The following is a description of a gene set: Human Gene Set: MASSARWEH_TAMOXIFEN_RESISTANCE_UP species: Homo sapiens Genes up-regulated in breast cancer tumors (formed by MCF-7 xenografts) resistant to tamoxifen. from publication Massarweh S, Osborne CK, Creighton CJ, Qin L, Tsimelzon A, Huang S, Weiss H, Rimawi M, Schiff R (PMID 18245484) Not all breast cancers respond to tamoxifen, and many develop resistance despite initial benefit. We used an in vivo model of estrogen receptor (ER)-positive breast cancer (MCF-7 xenografts) to investigate mechanisms of this resistance and develop strategies to circumvent it. Epidermal growth factor receptor (EGFR) and HER2, which were barely detected in control estrogen-treated tumors, increased slightly with tamoxifen and were markedly increased when tumors became resistant. Gefitinib, which inhibits EGFR/HER2, improved the antitumor effect of tamoxifen and delayed acquired resistance, but had no effect on estrogen-stimulated growth. Phosphorylated levels of p42/44 and p38 mitogen-activated protein kinases (both downstream of EGFR/HER2) were increased in the tamoxifen-resistant tumors and were suppressed by gefitinib. There was no apparent increase in phosphorylated AKT (also downstream of EGFR/HER2) in resistant tumors, but it was nonetheless suppressed by gefitinib. Phosphorylated insulin-like growth factor-IR (IGF-IR), which can interact with both EGFR and membrane ER, was elevated in the tamoxifen-resistant tumors compared with the sensitive group. However, ER-regulated gene products, including total IGF-IR itself and progesterone receptor, remained suppressed even at the time of acquired resistance. Tamoxifen's antagonism of classic ER genomic function was retained in these resistant tumors and even in tumors that overexpress HER2 (MCF-7 HER2/18) and are de novo tamoxifen-resistant. In conclusion, EGFR/HER2 may mediate tamoxifen resistance in ER-positive breast cancer despite continued suppression of ER genomic function by tamoxifen. IGF-IR expression remains dependent on ER but is activated in the tamoxifen-resistant tumors. This study provides a rationale to combine HER inhibitors with tamoxifen in clinical studies, even in tumors that do not initially overexpress EGFR/HER2., and this is the list of marker genes: NFIX, SDC1 (syndecan 1), EPN3, USP54, PTPN13, PLBD1, SAT1, COL5A2, VASN, CENPV, CREB3L2, ORMDL3, NUCB2, MTMR12, MYO1B, ALCAM, MIOS, DHRS3, STK38L (serine/threonine kinase 38 like), CD55, TENT5A, TLN2, RAD23B, LITAF, C6orf120, OTUD7B, SH3BP4, YIPF6, MIR99AHG, NUPR1, RFTN1, XPNPEP1, AR, JKAMP, CYB561, MIPEP, DIPK1A, EDN1, P2RY2, APELA, H2AC18, BCAP29, IDH1, NPR2, CCPG1, IQGAP2, POGLUT3, COL1A2, CDC37L1, TNS3, SYT7, KLF12 (KLF transcription factor 12), YIPF1, LIMCH1, ANKRD22, PIP4K2C, KLHL8, DNAJA4, B3GALT4, WDR45B (NCBI Gene Id 56270), TTC9, SHANK2, SGMS2, RORC, RELCH, CYP2J2, SLC12A5, SLC12A2, HOXA5, PRDM4, BET1L, PRPS1 (phosphoribosyl pyrophosphate synthetase 1), FAM210B, LOXL1, GAN, SCHIP1, CAB39, PDGFRA, ARHGEF37, FAM219B, SYNJ1, SCARA3, USB1, CFL2, AGMAT, ZNF70, ACVR2A, SFMBT2, DPY19L4, TYW5, TENT4B, RAB27B, MUC1, TIMM23B, SLC22A15, SRARP, FFAR2, FBXO6, SAR1B, EPAS1, TPMT, TXNDC5, TMEM50A, OSR2, EPS8L1, MTUS1, MTURN, ZNF704, IDH2 (isocitrate dehydrogenase (NADP(+)) 2), MTA3, PYM1, ATP2B1, RNF144B, RASL11B, FGD6, RAD18, DLX1, TSPAN1, EOGT, PMP22, GALNT3, C3orf70, CTSO, SWAP70, MUC2, ID2, ZFP36, PSTPIP2, SPRING1, LIMK2, SMIM7, MMAA, SQOR, TIMP2, SGPL1 (sphingosine-1-phosphate lyase 1), TACC1, TOMM40L, KIAA0513, NFIA, PITX2, UNC13B, ENC1, IRF2BPL, DOCK11, HOXC13, SLC37A1 (NCBI Gene Id 54020), PTPRJ, OXCT1, OLFML2B, USP53, GALNT1, TRIQK, PPM1L, TGFB2, CLCN3, ARRB1, STX12 (syntaxin 12), UQCC1, GUCY1A2, GPR157, GREB1L, CDH3, PRICKLE2, AGAP4, SASH1, KDELR2, OLFML2A, COBLL1, SMAP2, LRRC1, GNA12, CPD, MTERF4, INPP4B, SCCPDH, ZNF697, FHIP2A, KIAA1217, TRAK1, IER3, HOTAIRM1, GPC1-AS1, TMEM41B, GABARAPL1, MIGA1, COLEC12, HNRNPC, RASGEF1A, KRT13, ACACA, STN1, WDR90, TM9SF3, GAREM1, IL13RA1, KRT81, ATG2B, TRAF5, EMP1, HS6ST2, GADD45G, VPS13B, PTPN14, HOXA10, CBR1, MATN3, PRMT9, DENND3, RAB1A, DSCR8, SMPD1, H2BC4, DEGS1, TMEM39A, NIPAL3, RHOF, GATA2, MEF2A, LRRC8E, RND3, ACSL1, RASSF5, PSEN1, GFPT1, NEBL, PDXDC1, ADAM9, TNFSF10, HACD2, ERBB2, BMAL1, RICTOR, VSIG10, ATXN1L, SLC25A16, BCL6, H3-3B, RBMS1, LIMA1, PCTP, C6orf62, FAM13A, SNX13, SPTY2D1, MPZL2, PARM1, ATP8A1, LIX1L, WLS, S100P, IL1R1, SPINK4, BEX2, NCEH1, JAG1, ANOS1, LOX, FAM20C, SLC11A2, ZNF550, NUDT4, TRAM2, TRAM2-AS1, PLEKHA7, TMEM8B, MYCL, SKIL, TMEM50B, DYNLL2, S100A14, LYPD3, RBKS, CADPS2, GRIN2D, CYLD, BAIAP2, FAM114A1, HPN, HDLBP, TMEM131L, CRYM, SMIM14, TMEM135, ANXA3, ZNF827, ZNF295-AS1, DIDO1, CCDC149, TACSTD2, EPB41L4A, TBC1D8B, SPATA13, CGN, INPP1, PRRT3, CEACAM6, WDR26, TADA2B, PDGFC (platelet derived growth factor C), RASD1, MID2 (NCBI Gene Id 286440), EHD3, EBF1, MICB, TCEA3, CTNND1, CCNYL1, TBC1D8, TMEM199, DOCK5, CDS1, GOLT1B, TRAF4, LMCD1, GPR160, PSAT1, LINC02984, GPR39, RAI2, LINC01138, ALDH1A3, ARAP2, TMEM45B, MTSS1, H1-2, TWSG1, WNT3, MACC1, FLVCR2, ANXA7, NUAK1, FIBCD1, XK, FECH, SH3BGRL, MIR22HG, NUFIP2, MANSC1, CRYBG3, LNX1, TMCO3, NLGN4X, ZNF829, TCTA, AAK1, PBX3, THRB-IT1, SLC4A11, KRT80, ARAP3, PLPP5, NVL, RCAN1, FUT9, ADIRF, EIF2B5, SH2D4A, HSPA5, ATP2C2, ICA1, ABHD17C, PRTFDC1, QKI, TXNRD1, PDZD2, B4GALT6, ANK3, SLC20A1, PDE8A, SEC16A, DGLUCY, CAV2, NCOA1, ARHGEF28, FAS, TACC2, ALAD, AKTIP, RAB11FIP5, ERBB4, BTG3, HTR7P1, KRT7-AS, KCNMA1, CARD14, ARFGEF3, RSAD2, ABCC5 (ATP binding cassette subfamily C member 5), RGPD5, PLEKHS1, LACTB, CD164, SHISA9, CRISP3, SYCP2, PDXK, CDH11, ANKS6, TBC1D15 (TBC1 domain family member 15), ELL2, FSIP1, SMIM5, FXYD3 (FXYD domain containing ion transport regulator 3), PROM2, NANS, ASAH2, RNF103, RPS6KC1, LATS2, ASPH, KANK1, GALNT12, PBX1, SPAG1, IDNK, GSDMD, PKIA, FAM234B, IFT57, ZHX1, FUCA1 (alpha-L-fucosidase 1), TRIM62, TAPT1, BCAS1, DRAM1, RIPOR3, EPB41L4B, CAMK2G, NT5C2, RAB20, PAX9, CANT1, ENAH, MARK1, BZW1, TRIB3, GRAMD4, CDC14B, SAMD4A, IGSF3, DRAIC, GLRX, MFAP3L, RIN2, PTK6, PRAME, BBS4, FCHSD2, TMEM87B, PI4K2B, TP53INP2, PWWP3B, C2CD4D-AS1, BAMBI, FGF13, ATP2A3, ARF4, DIAPH2, EPB41L2, BCAM, SNAP29, CCNE1, CYSRT1, GLTP, COPZ2, ACAT1, GLCCI1, ANKMY2, SERHL, CAST, LGALSL, HOXB2, PLPP6, CHFR, RTP4, SCPEP1 (serine carboxypeptidase 1), PIK3R3, ABCC6, SIM2, KLHL7, LRPAP1, PDE4D, REXO2, L3MBTL3, KDELR3, YIPF5, PRODH, ACKR3, TJP2, DDR1, DENND2C, PLD1 (phospholipase D1), ACVR1, STOM, WDR20, KCNN4, RAP1GAP2, TMEM245, NECTIN4, SCYL3, MIA3, KLF4, THBS4, UTRN, SLC9A6, DNM3, B3GALT5, HEXIM1, IGFBP5, SLC44A2, LHFPL2, ROCK2, PPFIBP2, MFSD6, CERK, PTGFRN, BEX4, CD36, GATA3-AS1, HMGCS2, RND1, GAB1, CDK6, HID1, BLNK, LRATD1, ELF5, LURAP1L, GALNT10, RNF207, FZD4, CD46, RAPGEF2, FOXA3, SERHL2, MYLK, RPRM, MACO1, EYA2, DAG1, UBE2N, TMTC3, PSMB8, PACSIN1, DENND4A, RAB2A, ULBP2, CHP1, INPP5A, INHBB, CALML5, MPZL3, FERMT2, EZR, CSNK1E, FAM149A, CINP, TBC1D30, RIPOR1, PITPNM1, NET1, SMIM13, PRR15L, UGGT2, TRGC1, FAM171B, PREX1, MB, MGAT4A, WIPI1, KLF3, RDH10, MPPED1, RNF10 (NCBI Gene Id 9921), NIBAN1, IQCE, TMEM59 (NCBI Gene Id 9528), AQP3, LINC01588, GASK1B, CASP7, SLC41A2